The following is a description of a gene set: studied in species Mus musculus Mouse Gene Set: REACTOME_PI_3K_CASCADE_FGFR2 PI-3K cascade:FGFR2, and this is the list of marker genes: Fgf10, Fgf18, Fgf9, Fgf1, Gab1, Fgf5, Grb2, Fgf23, Fgf20, Fgf22, Fgf7, Fgf4, Pik3ca (phosphatidylinositol-4,5-bisphosphate 3-kinase catalytic subunit alpha), Fgf6, Fgf8, Fgf17, Pik3r1, Ptpn11, Fgf3, Fgf2, Frs2, Fgf16